The following is a description of a gene set: species: Homo sapiens The chemical reactions and pathways involving liposaccharide. Human Gene Set: GOBP_LIPOSACCHARIDE_METABOLIC_PROCESS, and this is the list of marker genes: B3GALT4, GM2A, GBGT1, PRKAA1, FUT1, MIR195, HEXA, NEU4, PGAP4, ST8SIA6, CWH43, B4GALT3, GAL3ST3, PIGH, LCT, ST3GAL6, PIGM, FUT2, PGAP3, PIGC, MPPE1, UGCG, GBA2 (NCBI Gene Id 57704), MIR127, PIGX, B3GALT1, UGT8, MIR16-1, GALC, GAL3ST1, ITGB8, ST8SIA5, ST3GAL5, FUT6, PIGK, B3GALNT1, ST6GALNAC4, SLC30A5, MFSD8 (NCBI Gene Id 256471), SCCPDH, PGAP2, PGAP1, PIGF, PIGO, PIGL, PIGN, TM9SF2, SUMF1, GPAA1, PIGW, B4GALNT1, PIGB, PIGS, B3GNT5, PIGG, CLN6, KIT (NCBI Gene Id 5086), GBA1, GAL3ST4, SCARB2, GBA3, C20orf173, B4GALT6, ST8SIA1, DPM1, GLB1 (NCBI Gene Id 2720), NEU2 (NCBI Gene Id 4759), AOAH, A3GALT2, GAL3ST2, ST6GALNAC5, B4GALT5, HEXB, PRKCD, PIGZ, LARGE1, A4GALT, PNLIPRP2, FA2H, FUCA1, PIGQ, ENPP7, ST6GALNAC6, ST6GALNAC3, NAGA, PIGP, PIGU, DPM2, M6PR, ABCA2, PIGY, SMPD1, DPM3, BAX, CERK, ST8SIA3, PIGA, NEU3, FUT9, FUT4, GLA, ST3GAL4, NEU1, ST3GAL1, B4GALT4, ST8SIA4, ST8SIA2, ST3GAL2, NAGLU, B3GALT2, CREM, ST3GAL3 (NCBI Gene Id 6487), PIGT, PIGV